Given this list of marker genes Mrpl19, Grpel1 (GrpE-like 1, mitochondrial), Phb1, Afg3l1, Apoo, Bax, Mtx2, Mpv17l2, Pdss2, Timm22, Tomm20l, Ndufab1, Ppif, Mrpl51, Mfn1, Mtx1, Etfdh, Timm44, Mrpl45, Mrps18b, Smdt1, Mrpl21, Pnpt1, Mrpl18, Mcu, Spg7, Mrpl33, Mrpl17, Samm50 (SAMM50 sorting and assembly machinery component), Tomm40, Supv3l1, Mrpl54, Mrpl43, Mrps18c, Timm50, Immt, Mrpl38, Mrps35, Mrpl36, Nfs1, Mrpl13, Tomm7, Vdac1, Mrps12, Mrpl11, Polg, Mrps6, Mrpl15, Clpx, Micu1, Mrpl23, Dnajc19, Aurkaip1, Micos10, Mrpl34, Mrps10, Fxn, Mrps2, Mrpl37, Isca2, Pam16, Mrps11, Mrps23, Chchd6, Polrmt, Timm10, Dap3, Agk, Mrps18a, Micu3, Mrps30, Nsun4, Tomm5, Mrpl9, Dnajc15, Mrps16, Mrpl24, Etfb, Mrpl47, Mrpl16, Mrpl46, Romo1, Apool, Lyrm4, Timm17b, Mrpl39, Grpel2, Mrpl28, Mrps9, Mrpl50, Hadhb, Gadd45gip1, Immp1l, Slc25a5, Trmt10c, Mrpl14, Mrps14, Timm21, Mrpl58, Mrpl27, Mrps31, Mrps33, Micos13, Mrpl40, Chchd10, Timm8a1, Prorp (NCBI Gene Id 66132), Mrpl42, Chchd3, Mrps17, Mrpl22, Hadha, Mrpl32, Timm9, Mrps22, Mrps26, Slc25a31, Mrpl48, Timm17a, Pmpcb, Micu2, Mrpl57, Mrpl41, Mrps24, Mcub, Mrpl10, Tomm6, Iscu, Timm23, Chchd1 (NCBI Gene Id 69738), Tomm40l, Mrpl3, Mrpl12, Mrps28, mt-Rnr1, Nsun3, Mrpl4, Timm13, Tomm20, Mrps21, Pdss1, Trmt10b, Mrpl55, Mrps25, Mrpl30, Mrpl52, Mrpl53, Mrpl44, Tomm22, Dna2, Mrpl49, Mrps34, Acacb, Dnajc11, Phb2, Ptcd3, Hsd17b10, Slc25a4, Mrpl20, Mrps15, Timm29, Timm10b, Mrpl2, Mrps7, Mterf4, Polg2, Mrpl35, mt-Rnr2, Afg3l2, Mrps5, Immp2l, Mrps27, Etfa, Mrpl1, Mtx3, here is a description of the gene set: species: Mus musculus A protein complex that is part of a mitochondrion. Mouse Gene Set: GOCC_MITOCHONDRIAL_PROTEIN_CONTAINING_COMPLEX